The following is a description of a gene set: Any process that results in a change in state or activity of a cell (in terms of movement, secretion, enzyme production, gene expression, etc.) as a result of an endothelin stimulus. Endothelin is any of three secretory vasoconstrictive peptides (endothelin-1, -2, -3). species: Mus musculus Mouse Gene Set: GOBP_CELLULAR_RESPONSE_TO_ENDOTHELIN, and this is the list of marker genes: Kdm6a, Crk, Sirt6, Bcar1, Prkd1